Given this list of marker genes TBX4, CEP152, CYP11B2, TGFBR1, CFAP58, FMR1, MCTP2, PCNT, STRA6, GP1BB, RAB3GAP1, ARCN1, WNT3, COL5A2, GPR161, KLF6, HNF1B, CKAP2L, CLMP, GH1, STX1A, HBA1, GATA6, USF3, CDC14A, TSR2, QRICH2, POLG, GRIP1, LSM11, ADAMTS3, FANCI, HESX1, DNAH8, GFM2, JAK3 (NCBI Gene Id 3718), GJB3, HROB, IL17F, NAF1, DACT1, SYCE1, USB1 (U6 snRNA biogenesis phosphodiesterase 1), LETM1, DKC1, RIPPLY2, FGFR2, ATP6V0A2, KIF21A, GMPPB, ATIC, PLA2G2A, TIAM1 (TIAM Rac1 associated GEF 1), CUL4B, ARX (aristaless related homeobox), ESAM, PTRH2, SIN3A, FAT4, DPM2, CHD7, TSHB, PRDM13, HS6ST1, ABCD4, TMEM237, DDX59, SLC19A2, CATSPER2, CRPPA, KLRC4, TYMS, MSH4, ARMC2, RNF135, MBD4, HPS6, GMNN, ADAR, MECP2, APC (APC regulator of WNT signaling pathway), FLG, STT3B, EHMT1, TBX1, SKI, RTEL1, ORC4, FLT1, WBP4, ERCC3, NKX2-5, KDSR, GRB10, HYLS1, PIGQ, KISS1R, PHF6, RNU12, CFAP91, BRDT, UBR7 (ubiquitin protein ligase E3 component n-recognin 7), NFIB, ANKRD11, MAD1L1, SDHD, LFNG, BBS4, HEATR3, ZFPM2, TSPY1, TCTN1, MBTPS2, CWC27, IL10RB, CEP19, DHX37, DCX, TMEM231, KDM1A, PAX2, SERPINA1, B4GAT1, TCTN3, TEX14, ERCC8, BTK, KRT5, EED (embryonic ectoderm development), GLE1, IFT81, BBS2, SMC1A, DVL1, RECQL4, PNLDC1, THOC2, OPHN1, STS, GNRH1, POLA1, LYN, TAC3, RAD50, POU1F1, NDUFS4, FUZ, SOS1, CDKN1B, LRRC23, IFT172, TWIST2, NPAP1, DHH (desert hedgehog signaling molecule), SOX18, PTPRJ, SSX1 (NCBI Gene Id 6756), CLCN4, PIEZO2, CCBE1, FBLN1, ZNF699, POGLUT1, LHCGR, SLC25A10, TRAIP, ROBO1, NDN (NCBI Gene Id 4692), SIAH1, RPL27, MID1, RPS15A, FKTN, DYNC2H1, DLC1, PEX3, OTUD6B, PNKP, TP53, DHODH, RBMY1A1, EIF2S3, DNAJC30, SMS, VPS37D, ATRX, XPC, PITX2, AXL, DPH2, CIDEC, RARB, INPPL1, WNT7B, FDXR, VPS13B, SRY, KCNQ1, GJA1, SEMA3A, HRAS, SMARCD1, SLC32A1, SGPL1, KAT5, NF1, AP1S2 (NCBI Gene Id 8905), IDH1, PROKR2, PBX1, OCRL, HPSE2, CFAP74, HARS2, MTOR, HEPACAM, HERC2, MUTYH, EPHB2, ADARB1, UBE2T, MAPK1, CYP17A1, HNF1A, FREM1, BARD1 (BRCA1 associated RING domain 1), BDNF, PIGG, WEE2, FKRP, CFAP44, MMP14, KCNA1, G6PC3, KLF1, ABCB7, TCF4, GRIN2B, POLR3H, CAVIN1, RORA, ADGRG2, MAP3K1, INSL3, HSD17B4, SMOC1, RABL3, WRN, THSD1, CEP290, RPS26, CHST14, SCN1B, MOGS, ZFTA, PWRN1, CFAP43, POMGNT1, ARID1A, RPS6KA3, FOXL2, GNAO1, TAF6 (NCBI Gene Id 6878), PEX1, RPS20, FAS, TRPM3, DYNC2LI1, ANGPT2, CYP11B1, GAS1 (growth arrest specific 1), PLAAT3, KAT6B, SKIC3, PRKACA, PACS1 (phosphofurin acidic cluster sorting protein 1), MAF, C4A, RNF212, SOX2, AXIN2, SF3B4, SOX3, KCNQ1OT1, AKR1C2, ORC6 (NCBI Gene Id 23594, origin recognition complex subunit 6), RNASEH2A, FLRT3, STAR, PLVAP, PEX6, RAD51D, UPB1, NECTIN1, PRLR, XRCC4 (X-ray repair cross complementing 4), HFE, THOC6, RPGRIP1L, SOX11, GJB4, SLC18A3, SOX10, FANCD2, SOX4 (NCBI Gene Id 6659), RPL8, GTF2IRD1, CCDC146, PALB2, GFRA1, MAP3K7, NPM1, STAG1, CHD6, RBM10, PIK3R1, DAZ3, ZDHHC9, MLH1, RAC1, CDH2 (NCBI Gene Id 1000), CATIP, TBL2, DCLRE1C, KLHL40, GATA3, FBN1, TUBA1A, AFF4, TMEM94, LRIG2, IFT27, RYR1, BRAF, MYT1L, SCYL2, USP7, SEMA3E, CDH1, RIPK4, SPRED1, MRPS22, SMARCA2, CCDC28B, CDON, HNRNPR, MPLKIP, MAMLD1, KCNN3, MCC, TINF2, DPP9, TWNK, ROR2, LIPE, RAD21, RPL35A, SUFU, TAF4B (NCBI Gene Id 6875), UBAC2, WDR35, TRRAP, FARSB, SLC39A4, PHGDH, RXYLT1, IRF6, PRKACB, B9D2, PTPN12, CDH11, UQCC2, SPRY4, SLC16A2, RNASEH2C, OPCML, NDNF, FANCB, NEK1, RAPSN, EBP, LMX1B, GRIA2, ZBTB20, DDX3X, FLNA, HHAT, PPFIBP1, NIN, IGKC, IER3IP1, MED11, IFT74, FOXA2, PAFAH1B1, SLC35D1, CPLANE1, RPL5, AKT2, RAD54B, TCOF1, LMNB2, CCDC174, CFAP70, ZPR1, SEC24C, HUWE1, CHD8, KIF7, SMARCC2, TRIP13, NSMF, FANCG, TRAF3IP2, PSMC1, SRCAP, BMPR1A (bone morphogenetic protein receptor type 1A), F7, SETD2, CCDC34, NUP107, TRIM28, NDUFB7, HCCS, GJC2, GATA5, MDM2, IGBP1, SNORD115-1, SETD5, TBC1D20, NFIX, KCNH1, DLX4, KDM5B, FANCL, KIAA0753 (KIAA0753), ACBD6, TP63, PHACTR1, CLDN2, HDAC8, KEAP1, TXNDC15, OFD1, ELN, IQCN, STOX1, FBXO11, MKKS, NDP, PLG, NEB, DNAH2, STT3A, VPS50, POLR1B, ARMC9, ASH1L, ALOX12B, IL17RA, PAX6, CCDC62, BRF1, SUZ12, INSR, TACR3, PHF21A, CEACAM6, DPAGT1, FSHB, POLR1A, PANX1, KLLN, DPYSL5, RSPO1, PPP1R12A, PWAR1, BMP15, CEP41, COL14A1, DNHD1, CAV1, ESR2, STAT6, CCIN, BRD4, MCM5 (minichromosome maintenance complex component 5), SLX4, RNU7-1, TERB1, TBX22, COG5, MNX1, BBS12, PI4KA, NODAL, ARID2, IDH2, SMG8, TFAP2A, SOHLH1, NEDD4L, DAG1, STAC3, ZMYM3 (NCBI Gene Id 9203), BAX, STRC, MSH2, FOXC1, SCN2A, DNM2, PRTN3, SHOC1, TMEM270, LMOD1, SPATA16, SUCLG1, FXR1, ERMARD, KMT2E, UBE4B, AUTS2, RBMX, GHR, FIG4, WNT7A, CHRM3, EDEM3, FGFRL1, FBXW7, GLI3, FOXE1, HMGA2, ANAPC1, CPLX1, TXNRD2, PNPLA6, CPE, SETD1A, RRAS2, SLC26A2, HSD17B3, PPARG, MBD5 (NCBI Gene Id 55777), IGF2, GNRHR, LARP7, FSHR, MECOM, MEG3, KLHL41, PIGP, DEPDC5, ALG9, HIBCH, CITED2, POMK, CCR1, KAT6A, XPA, SLC34A2, MT-CYB (mitochondrially encoded cytochrome b), GPC4, SLC25A22 (solute carrier family 25 member 22), PRDM16, METTL23, DNAJC19, IL23R, RPS28 (ribosomal protein S28), KMT2A (lysine methyltransferase 2A), NR2F2, PORCN, PRKN, COL3A1, BRCA2, GPC6, KDM5C, SMARCAL1, DCC, LHX1, CDC45, FLCN, SC5D (NCBI Gene Id 6309), TGFB2, BMP6, DAZ1, SMC3, KCNJ6, FOS, NIPBL, HNRNPH1, BUD23, TUBB8, FGF17, NOTCH2, CFAP61, PRKAR1A, LARS2, KATNIP, EVC (NCBI Gene Id 7886), MEIOB, DIS3L2, IL12A-AS1, SALL1, HSPG2, HLA-DRB1, NHLH2, CC2D2A, TGDS, ACTL9, DHCR24, ZIC2, KIF14 (NCBI Gene Id 9928), MAB21L2, MYH11, IL17RD, FLI1, MOV10L1 (NCBI Gene Id 54456), LUZP1, HPRT1, HGD, ZMYND15, ITPR1, PHIP (NCBI Gene Id 83843), AXIN1, SOX5, CD96, ADH5, PLCB4 (NCBI Gene Id 5332), RNASEL, AARS1, DHCR7, OTX2, CYB5A, PTEN, PHKG2, ACTL7A, TSGA10, CEP112, ATP6V1E1, HDAC4, CILK1, FGFR3, PEX10, POLR3K, MIF (macrophage migration inhibitory factor), POU3F3, WASHC5, RAB3GAP2, WFS1, PPP2R1A, SMARCB1, STAG3, RRAS, TCF12, TUBB, LAS1L, B3GLCT, FANCM, PTPN11, WT1, GATA2 (GATA binding protein 2, NCBI Gene Id 84724), H4C5, EZH2, DUSP6, CCDC32, VPS35L, CREBBP, COQ6, PLIN1, NXN, PROP1, TMCO1, SIL1, PIGN, LRP2, DCAF17, ASXL3, BBS1, USP9Y, GTF2IRD2, RPS24 (ribosomal protein S24), LAMA5, SIM1, CFAP65, TBCD (NCBI Gene Id 6904), SIK1, RSPO2, PDGFRL, BTNL2, PUF60, KCNAB2, APC2, CTBP1, RREB1, TOPORS, RTL1, ANKLE2, ATP6AP2, RAF1, FAM111A, PSMD12, TMEM70, TTC29, TBCE, CDK8, NELFA, CTLA4, TGFBR2, RPS27, BRIP1, ORC1, NBN (NCBI Gene Id 4683), B3GALNT2, GATA1, AHDC1, GAD1, RPL9, LARGE1, WDR62, RIN2, WDPCP, RPL15, NDUFA8, POLR1D, GREB1L, NAB2, OGT, CLCA4 (chloride channel accessory 4), TWIST1, SLC35A2 (solute carrier family 35 member A2), PSENEN, RNU4ATAC, AK7, PHKA2, CHD4, POLD1, MED25, CUX1, PAX7, ODC1, RPL11, KDM6A, ISL1, ADAT3, HLA-DPB1, CCND1, MLXIPL, AGPAT2, RNF43, SPACA1, UBE3B, MEFV, TBC1D24, AURKC, OCA2, ERCC2, PPP2R3C, SATB2, STK11, PROK2, CTNNB1, SLC6A14, ANOS1, EXT2, TEKT3, TBX3, BLTP1, CT55, CDKN1C, ZSWIM7, TBCK, UFD1, FZD2, NDUFA6, B9D1, DYNC2I2, BUB1B, BSCL2, DICER1, IFIH1, DMRT1, LMNA, DSE, IL10, PRIM1, TEX11, RFX7, CLPP, PDE11A, SPEN, AAGAB (alpha and gamma adaptin binding protein), HOXA13, SLC9A3, PPP1CB, PIK3CA, MYL11 (myosin light chain 11), ANK1, USP26, MASP1 (MBL associated serine protease 1), ALG8, CYP11A1, FBXL4, NSD1, CEP120, CYLC1, MMP2, DGCR8, ARL6, NCF1, MYMK (NCBI Gene Id 389827), TCTN2, MKS1, LEPR, ERAL1, FTO, FANCA, PDPN, KCNN4, RAD51, NALCN, CDT1, ZFHX3, LIMK1, TLR4, DMPK, BMP4 (NCBI Gene Id 652), ACR, RPL31, C14orf39, RPS29, CYP21A2, GABRD (gamma-aminobutyric acid type A receptor subunit delta), LZTR1, STK33, DZIP1, CLIP2, PAX3, CDCA7, RAB18, CSPP1, RERE, GDF6, CFAP47, BAZ1B, FEZF1, EFNB1, ALDH1A2, WRAP53, RAC3, MXI1, FOXH1, TAF4, CHEK2, TPM2, CHRNG, C2CD6, FLT4, UPF3B, DGCR2, RPS17, TSPYL1, DISP1, LRPPRC, DNAJC21, PDE6D, RPGRIP1, POLR3A, DAZ4, LZTFL1, FGF8, SLC31A1, TASP1, FOCAD, WNT5A (NCBI Gene Id 7474, Wnt family member 5A), USP9X, GRIA3, IL17RC, HOXD13, IFNGR1, HFM1, FSIP2, DMXL2, SPRED2, KCNU1, KLHL10, RPL18, KMT5B, PMS2, KDM3B, JAM3, LIG4, FANCE, COL7A1, DDX6, SDCCAG8, SPECC1L, MYOD1, DCTN4, AMHR2, PEX16, SEC23B, POGZ, HNRNPK, JMJD1C, MED13L, DNAH1, FLNB, WDR11, SPTBN1, MAPRE2, CHRNA3, CTC1, CUL7, H4C9, TOGARAM1, NSUN2, CEP57, PMFBP1, EFEMP1, FBXO43 (F-box protein 43), EIF5A, RPL26, FARS2, COMT, TARS1, MESP2, PYCR1, PEX19, GNA11, EPCAM, SNORD116-1, DPM1, TLR2, PLAG1 (NCBI Gene Id 7996), RFC2, DTYMK, CBL, ARNT2, DOK7, SMARCE1, KIAA0586, SYNE1, CLIC2, VAC14, PMS1, ALKBH8, HLA-DPA1, CCDC8, ITGA8, MC2R, CASZ1, ERCC6, ACTA1, RNF113A, TMEM216 (NCBI Gene Id 51259), ARL6IP6, DLK1, DDB2, DYRK1A, GRM7, MYF6, RFWD3, TONSL, C2CD3, MSX1, ALX4, ATP6V1B2, CYP19A1 (cytochrome P450 family 19 subfamily A member 1), TMEM107, DNALI1, COL1A1, EMG1, ATR (NCBI Gene Id 57307), POR, ARID1B, ATAD3A, TTC21A, ALOXE3 (arachidonate epidermal lipoxygenase 3), SEC23A, WNT9B, TMEM67, SLC11A1 (solute carrier family 11 member 1), FIGLA, DLL1, INTU, EVC2, SOS2 (NCBI Gene Id 96829), GRIN1, TGFB1, TGFB3, COL4A6, RBM8A, SLC26A9, TRIM32, GCLC, RPL10L, BBIP1, COLEC10, ALDH18A1, ZMIZ1, MLH3, NKX2-1, ALK, NTHL1, MSH3, RPS10, MTM1, ECE1, CARS1, MED12L, FKBP6, AKR1C4, MAGEL2, GATAD2B, BBS9, RASA2, GJA5, MRAP, SPATA22, DCHS1, NEUROD2, AMH, MTMR14, SPAG17, TNXB, FILIP1, POMT1, PSMC3IP, SIX3, DRC1, PDHA2, UBA1, WDR37, CRIPTO, ACTA2, IPO8, AR, TERB2, MDFIC, TALDO1, WNT10A, MRPS28, FGF20, HERC1, DDB1, EPG5, ZMPSTE24, RIT1, CTU2, FGF10, BRWD1, PQBP1, SLC25A24, SPIDR, KDM6B, DNA2, DLL3, BBS7, MYC, ALG12, FRAS1, FDFT1, H1-4, GGN, KDR, KLHL15, FAM149B1, STXBP1, CDC42BPB, MRE11, KANSL1, PMM2, AKT1, RNASEH2B, MYMX, TSC2, PRMT7 (protein arginine methyltransferase 7), COG1, SOX9, NOP10, PIK3C2A, SHOC2, SLC30A7, NR3C1, TBX6, PEX2, SEMA4A, GALT, DVL3, GREM1, PATL2, PSMB8, SETBP1, BRCC3, NR5A1, HMOX1, MKRN3, ATN1 (NCBI Gene Id 1822), HYMAI, TGIF1, GTF2E2, NNT, H19, RTTN (rotatin), MADD, RLIM (ring finger protein, LIM domain interacting), GTF2I, TNFRSF1A, CFAP251, SMO, ERAP1, PTDSS1, TERT, ADA2, EBF3, TAPT1, NDUFB11, YY1, GK, PLAGL1, LHX4, VANGL1, YWHAE, TREX1, HOXC13, EIF4A2, GDF1, XYLT2, NUP88, PEX11B, MED12, LMOD3, DNAH17 (dynein axonemal heavy chain 17), GPC3, MYRF, COL5A1, TRIM8, REST, FANCC, NAA10, CLCN3, ZPBP, SRRM2, IL12A, MAP2K2, CEACAM3, CCNQ, SCLT1, SHH, PACS2, SEPTIN12, ATM, UNG, MCM8, MEGF8, HSD3B2, AKAP3, CXCR4, SUN5, ATP6V1A, ECEL1, FREM2, DPY19L2, WWOX, PTPRF, AURKA, RPL10, PIEZO1, RET, ADNP, RELA, CDC73, TSC1, TRIP4, NHP2, PRPS1, SIX6, JAG1, PUM1, FOXF1, SMAD4 (NCBI Gene Id 4089), POMGNT2, ESS2, EDNRA, SAMD9, BIN1, SMAD3, CDKL5, DNAH10 (dynein axonemal heavy chain 10), EIF4H, CCDC22, CLP1 (cleavage factor polyribonucleotide kinase subunit 1), MAX, PSMB10, HLA-B, COX7B, MUSK, DNMT3A, MAB21L1 (mab-21 like 1), XRCC2, OBSL1, PEX5, SALL4, WNT4, ADAMTS15, MSH5, MYH3, SSR4, SPEF2 (NCBI Gene Id 80192), TEX15, CDKN2A, SRD5A2, RAB23, IGHG2, PSPH, SMARCA4, VAMP7, CASK, ERBB2, DNAH7, ERCC4, DGCR6, POFUT1, OTUD5, NEXMIF, DYNC2I1, EP300, NOTCH3, KRAS, NRAS, DAZ2, DPF2, VEGFC, CDC6, SCAPER, NSD2, TDRD9, KMT2D, CAPN15, ZFX, ANTXR2, BLM (BLM RecQ like helicase), NPHP1, FANCF, PAICS, MRAS, ZSWIM6, PHKB, PRKDC, CBX2, PARN, POMT2, NKX2-6, PPP1R15B (NCBI Gene Id 84919), PEX26, MAP2K1, GLYCTK, NONO, HBA2, GBA2, NR0B1, BBS5, FERMT1, CFAP418, LMBR1, CFAP69, DDX3Y, PIGL, TNRC6B, SPINT2, POU6F2 (NCBI Gene Id 7968), IL1RAPL1, TTC8, CDC42, BBS10, PIGS, BUB3, DHDDS, SRA1, TRPV6, SDHC, PEX14, ESR1, UBR1, TOE1, FGD1, GTF2H5, COLEC11, CTDP1, LHB, NF2, HID1, SMAD2, PRRX1, STAT4, GATA4 (NCBI Gene Id 2626), SMCHD1, NKAP, PIGA, ERCC1, POLR1C, POLE, TBX15, CLEC7A, PEX12, PDE4D, METTL27, KISS1, GLI2 (NCBI Gene Id 50806), FH, WNK3, AEBP1, CAMSAP1, HIRA, MINPP1, SYNGAP1, PTCH2, GSTM3, SLC37A4, SAMHD1, TBL1XR1, RPL35, VHL, SCUBE3, NOBOX, CAMK2A, RBBP8, ACTG2, BNC1, CFTR, GSC, COL4A5 (collagen type IV alpha 5 chain), GNAS, PHF8, LEP, COL4A1, MYLK, PTPN22 (NCBI Gene Id 5779), SRC, BUB1, TERC, H4C11, SLC29A3, ALMS1, INPP5E, GLI1, PEX13, MAD2L2, PALLD, ZNF462, SLC6A17, SYCP3, IRX5, BCOR, EWSR1, ZEB2, MMP23B, ACTB, ARHGAP31, RAD51C, SDHB, GNB2, BICRA, HS2ST1, ZMYM2, BMP2, HES7, TTC5, CTCF, ERCC5, UBE2A (NCBI Gene Id 7319), BRCA1, FGFR1, ABL1, RPS19, WDR19, NANOS1, CORIN, BMPR1B, BRWD3, MSH6, LSS, RPS7, KIFBP, POC1A, PRKCZ, CCDC141, AGA, PTCH1, LONP1, B4GALT7, ESCO2, TMEM63A, CENPT, TNFAIP3, IFT80, SNRPN, ARVCF, here is a description of the gene set: species: Homo sapiens Human Gene Set: HP_ABNORMAL_REPRODUCTIVE_SYSTEM_MORPHOLOGY A structural or developmental anomaly of any of the tissues involved in the genital system. Abnormal reproductive system morphology